Given this list of marker genes ZFP36, HNRNPAB, DHX36, ZFP36L1, PUM2, here is a description of the gene set: Human Gene Set: GOBP_REGULATION_OF_INTRACELLULAR_MRNA_LOCALIZATION studied in species Homo sapiens Any process that modulates the frequency, rate or extent of intracellular mRNA localization.